The following is a description of a gene set: Human Gene Set: MIR1825 from publication Chen Y, Wang X (PMID 31504780) species: Homo sapiens Genes predicted to be targets of miRBase v22 microRNA hsa-miR-1825 in miRDB v6.0 with MirTarget v4 prediction scores > 80 (high confidence targets)., and this is the list of marker genes: RAB7A, PI4KA, ARPP19, COL5A3, ARL4A, SULF1, KIT, PHF20, TMEM217, CPZ, RPS6KB1, HSPA12A, MYRF, SLC38A2, NSG1, GPCPD1 (glycerophosphocholine phosphodiesterase 1), DDR1, GCNT2, CRIM1, EPS15, PRDM16, BEND6, TRDN (NCBI Gene Id 10345), RCC2, ENTREP3, MED12, SLC45A3, CELSR1, ROCK1, PDE7A, NLK, SHOC2, SS18, PIGZ, NPAS2 (NCBI Gene Id 84195), TUBG1, REEP2, TAF5L, TBL1XR1, ZFP82, CEP63, NRP1, SLC2A12, RTN4, TGFBRAP1, USP38, GCFC2, ATG14, SPIN1, SOX6, UBE2L6, POGK, CNOT6, AGO4, DHX58, BCL7A, GPATCH8, ADGRA2, IPO8, CCDC88C, TLCD5, WASHC2A, PHIP, HHIP, ATP1A2, NFIL3, SNAPIN, RPS6KA5, TSPAN6, SLC35F1, SLC25A23, ZNF763, LDOC1, TGFBR1, NAA40, ZNF462, TIGD5 (NCBI Gene Id 84948), RASSF2, PKN2, C5orf24, TRIM2, DPPA4, ULK3, KMT2E, ZNF551, ZBTB20, SERPINE1, SLC24A3, ITCH, DYNLL2, ZNF773, ERLIN1, ARHGEF5, FUT9, TIAM1, NCSTN, AGAP1, IPO7, ETS1, CHRFAM7A, FLRT3, RC3H1, MITF, MBNL3 (NCBI Gene Id 55796), BBOF1, ARMT1, PPAN-P2RY11, FZD4, ITGA3 (integrin subunit alpha 3), LRAT, PHACTR2, SNN, VPS13A (NCBI Gene Id 23230), GPRC5A, SMIM3, MACIR, MDGA2, AQP11, SCAF11, INO80D, NAA15, ACACA, MYOZ3, VPS26A, PWWP3B, UHMK1, LIN7C, STRADB, UBALD2, NBL1, PKD2L2, CACNB2, RAD23B, CREB3L2, RBM24 (NCBI Gene Id 221662), LSM14A, CHD7, NOTUM, ACTG1, OSR1, ABCA1, ARHGAP12, REL, CLCN3, ZNF584, ATP2B4, JPH3, FAM20A, WASHC2C, ATG4D, NPTX2, ZNF544, RUNX2, RAB40C, TSPOAP1, ZNF488 (NCBI Gene Id 118738), ZNF740, PTPMT1, MRPS11, CEP350, ARHGAP21, AGO1